Given this list of marker genes NR3C1, EPAS1, PTK6, PELP1, HIF1A, here is a description of the gene set: Levels of PTK6 increase under hypoxic conditions due to direct transcriptional regulation of PTK6 gene by hypoxia inducible transcription factors (HIFs) (Regan Anderson et al. 2013). PTK6 protein levels are also rapidly stabilized in hypoxic conditions in a HIF-independent manner. It has also been shown that PTK6 is ubiquitinated in normoxic conditions by a so far unknown E3 ligase. part of: Signaling by PTK6 studied in species Homo sapiens Reactome Pathway: PTK6 Expression